The following is a description of a gene set: studied in species Homo sapiens Human Gene Set: chrXq11, and this is the list of marker genes: ARHGEF9, PFN5P, ARHGEF9-IT1, KPNA4P1, RN7SL799P, SPIN4, MTMR8, BLOC1S2P1, MIR1468, ZC4H2, ENSG00000288661, BTF3P8, PRXL2CP1, SSBL2P, AMER1, ASB12, SPIN4-AS1, YWHAZP7, GRPEL2P2, ZFRP1, KRT8P27, CCT4P2, MTND2P25 (MT-ND2 pseudogene 25), MTND1P31, HNRNPDP1, CBX1P1, MORF4L1P5, SHC1P1, ZC3H12B, LINC01278